Given this list of marker genes CMPK1, CAD, UMPS, MTOR, CPS1, DHODH, here is a description of the gene set: studied in species Homo sapiens Human Gene Set: GOBP_DE_NOVO_PYRIMIDINE_NUCLEOBASE_BIOSYNTHETIC_PROCESS The chemical reactions and pathways resulting in the formation of pyrimidine nucleobases, 1,3-diazine, organic nitrogenous bases, beginning with the synthesis of a pyrimidine ring from simpler precursors.